The following is a description of a gene set: The chemical reactions and pathways involving a pyrimidine nucleotide, a compound consisting of nucleoside (a pyrimidine base linked to a deoxyribose or ribose sugar) esterified with a phosphate group at either the 3' or 5'-hydroxyl group of the sugar. Mouse Gene Set: GOBP_PYRIMIDINE_NUCLEOTIDE_METABOLIC_PROCESS species: Mus musculus, and this is the list of marker genes: Nme6, Tbpl1 (TATA box binding protein-like 1), Nt5c, Dpyd, Nme4, Uprt, Cmpk1, Uckl1, Cad, Dhodh, Dhfr, Upb1, Nme2, Nme1, Nme7, Entpd4b, Dut, Upp2, Ak9, Shmt2, Nme3, Shmt1, Dck, Upp1, Umps, Dctpp1, Tyms, Entpd5, Uck2, Tymp, Ctps2, Ctps1, Nme5, Dpys, Entpd4, Uck1, Dctd, Cmpk2, Enpp3, Nt5c3, Slc4a7, Dtymk, Cda, Ak3, Nt5m, Entpd7 (ectonucleoside triphosphate diphosphohydrolase 7)